Given this list of marker genes Leo1, Paf1, Ctr9 (CTR9 homolog, Paf1/RNA polymerase II complex component), Cdc73, Skic8, Rtf1, Pex2, here is a description of the gene set: Mouse Gene Set: GOCC_CDC73_PAF1_COMPLEX A multiprotein complex that associates with RNA polymerase II and general RNA polymerase II transcription factor complexes and may be involved in both transcriptional initiation and elongation. In Saccharomyces the complex contains Paf1p, Cdc73p, Ctr9p, Rtf1p, and Leo1p. species: Mus musculus